Given this list of marker genes CKS1B, MATN2, RRAGB, CCDC85A, RCHY1, RAC2, NETO1, TBCA, BTG1, ZNF138, NAP1L1, GCSAML, APELA, AQP4, FLI1, TARS1, ZNF117, DLST (NCBI Gene Id 1743), BICC1, ZNF765, KAT2B, PAFAH1B2, HERC3, ADGRV1, MMAA, CPEB2, CDKL4, TMEM178A, ZHX2, CCND2, SLC17A6, TLNRD1, CCDC60, SORT1, FAM135A, AMIGO2, DSE, NTRK2, CNTN4, MYH10, TANC2, MARK1, ADD3, HSPA5, SIRT7 (NCBI Gene Id 51547), STK38L, ZFP90, DIAPH3, SP4, TLCD3A, NAA15, DHTKD1, XAF1, PLXDC2, TMEM38B, ZNF764, ARHGAP12, RAD23B, TMEM132C, KIF13A, EML4, IKZF2, ZFAND3, MYO6 (NCBI Gene Id 4646), ZDHHC11, SMARCC1, STK17A, GOLGA7 (golgin A7), PPP4R2, MBTD1, ZC3H12C, CNOT6L, CABLES1, UBR3, MAOA, ELL2, TDP1, TFCP2, PPP3CA, BLTP3A, ZNF99, MAP3K1, ZNF676, KCNMB2, ZNF107, PTPN12, GTDC1, OGT, MNX1, PDCD2, GMFB, ZCCHC2, CPEB3, PBX1, SAMD3, RBM46, IPMK, AKIRIN2, NUDCD1, BAZ1A, here is a description of the gene set: from publication Chen Y, Wang X (PMID 31504780) species: Homo sapiens Genes predicted to be targets of miRBase v22 microRNA hsa-miR-770-5p in miRDB v6.0 with MirTarget v4 prediction scores > 80 (high confidence targets). Human Gene Set: MIR770_5P